Given this list of marker genes KCNN2, ZFHX3, WBP1L, ZNF711, MAP2K5, LETM1, ZFAND5, WNT10A, IP6K1, CHD6, RAB27B, ADAMTSL5, ADAMTS8, EWSAT1 (Ewing sarcoma associated transcript 1), ANKHD1, RASIP1, TREX2, RAP2C, RASA4, DACT2, GLG1, KDM2A, CPNE1, MYPN, KCNJ15, CDH16, TUG1, OVOL1, TBC1D10A (TBC1 domain family member 10A), FKBP4, ROCK2, PI4K2A, CPEB3, DNAJB4, SLC4A7, B3GALT2 (NCBI Gene Id 90195), B4GALT3, GREB1, SLC10A2, TPM3, LRATD2, BRAF (NCBI Gene Id 673), GNAS, GABARAPL2, CHMP3, EEF1A2, COX6C, DNMT3A, TEX35, MRPL27, TOR1AIP2, BARHL1, PLEC, TUBA8, CHRDL1, GAD2, HCN4, ALDOA, TBX6, ZNF792 (zinc finger protein 792), PIGW, ANKRD2, IRAG1, RANBP9, SLC16A6, NLK, CELF1, WNT8B, ATP6V1A, BAIAP2L2, LCP1, MICALL1, MACO1, WWP1, MASP1, RCOR2, WNT4, MAP1LC3A, MID1, B4GALNT1, PPM1N, FAM174B, SLC25A1, TFAP2C, STEAP2 (STEAP2 metalloreductase), MROH7, TMEM53, ROM1, ADCYAP1, TTLL11, BZW2, CARMIL3, CAMKK2, KLHL34, MAML3, MYO19, XPNPEP1, LPL, ARF5, HOXA5 (NCBI Gene Id 55953), ATP1B4, SORBS2, PNPLA2, LDB2, NUFIP2, NAA50, WNT8A, DAXX, DUSP4, ATP5F1A, KCNH5, TCF7L2, DUSP3, ZFP36L1, SMPX, TTBK2, NLGN2, GALNT15, SMCR8 (SMCR8-C9orf72 complex subunit), EME1, LRFN4, F13A1, SOCS2, ZBTB20, ELAVL4, IER5L, ATOH1, SAG, YTHDF3, ERN1, RARA, KMT2E, BCL6, OAZ2, MYADM, SART3, ZNF503, RCOR1, GFPT2, SPRY2, PHF1, AOC2, CLEC11A, ZIC2, SLC38A2, SCML4, MTDH, FBXO40, WNT3, NPAS2, ARHGEF37 (Rho guanine nucleotide exchange factor 37), CKMT1B, TLX3, KCNJ2, ZNF827, FGF9, CIDEC, FST, SRGN, COL10A1, COX7A2L, SPATA7, LINC00310, NUDT4, FBXW4, SP6, SLC7A3 (NCBI Gene Id 84889), KCNIP4, SARNP, OSR1, PGF, NFKBIA (NCBI Gene Id 4792), GARIN2, DLG2, PDGFB, NKX6-1, CNNM2, DCX, NKX6-3, SPTAN1 (NCBI Gene Id 6709), PICALM, PMFBP1, ABL1, NDRG2, SOX15, LOX, PGAP4, FDX2, LINC01565, CD37, RBMXL2, RB1CC1, SLC25A3, GPC4, PRDM13, MAPK6, MAP2K7, MAP1A, LPAR4, NR2F2, ISCU, JMJD1C, SEH1L, CHAT, CIC, JPH2 (junctophilin 2), FAM193B, EML3, LMNTD1, DOLPP1, SATB1 (SATB homeobox 1), OAZ3, MXI1, PRKAA2, OVOL2, USP12, WNT5A, PSMF1, RGS9BP, GCM1, EEF1B2, OTUD7B, OS9, SEMA4G, LYSMD2, ESRRB, EAPP, RASGRF1, SCHIP1, PTCHD1, PLAC1, VGF, GPR3, INVS, CA4, TEF, ANKHD1-EIF4EBP3, WNT9B, SLC26A9, AGPS, NDUFS1, PHF21B, PGLYRP2, MINDY1, TOMM40, MARCHF5, HEXIM2, CLOCK, DKK2, UBE2R2, GDPD1, TRPS1, PMP22, SLC20A1, FSBP, GARIN3, NR2F1, UBQLN1, ALKBH6, REST, COMMD3, CYRIA, AK2, ITGB8 (NCBI Gene Id 3696), CCDC136, GFAP (glial fibrillary acidic protein), ESRRG, CKM, MEOX2, EIF1AX, CCSER2, BMPR2, CDC14A, PRUNE1, BTBD3, CTU1, LOXL4, ATP6V0A4, MIR9-1HG, CLUH, LOXL3, PPARA, LINC01101, SLC35B1, here is a description of the gene set: species: Homo sapiens Genes having at least one occurrence of the motif NNARGNCANNNTGACCYNN in the regions spanning 4 kb centered on their transcription starting sites. This matches the ESR1 transcription factor binding site V$ER_Q6 (v7.4 TRANSFAC). Human Gene Set: ER_Q6